The following is a description of a gene set: species: Mus musculus Mouse Gene Set: GOBP_POSITIVE_REGULATION_OF_MICROGLIAL_CELL_ACTIVATION Any process that activates or increases the frequency, rate or extent of microglial cell activation., and this is the list of marker genes: Lrrk2, Ctsc, Ttbk1, Stap1, Tafa3, Kcnn4, Trem2, Mmp8